Given this list of marker genes KCNMB3, KCNN4, KCNN2, KCNMA1, KCNMB1, KCNMB2, KCNN3, KCNN1, KCNMB4, here is a description of the gene set: species: Homo sapiens Ca2+ activated K+ channels Human Gene Set: REACTOME_CA2_ACTIVATED_K_CHANNELS